Given this list of marker genes Foxa1, Dusp6, Fgfr2, Rdh10 (retinol dehydrogenase 10 (all-trans)), Mbp (myelin basic protein), Fst, Hmgn3, Fgf10, Hoxb9, Maob, Bcl2l1, Lhx6, Edn1, Vldlr, Slc39a8, Fgfr3, Hoxa10, Trim2 (NCBI Gene Id 80890), Pnoc, Tle1, Trmt9b, here is a description of the gene set: Predicted targets of SOX9 that are up-regulated during early prostate development. Mouse Gene Set: SCHAEFFER_SOX9_TARGETS_IN_PROSTATE_DEVELOPMENT_UP species: Mus musculus Cancer cells differentiate along specific lineages that largely determine their clinical and biologic behavior. Distinct cancer phenotypes from different cells and organs likely result from unique gene expression repertoires established in the embryo and maintained after malignant transformation. We used comprehensive gene expression analysis to examine this concept in the prostate, an organ with a tractable developmental program and a high propensity for cancer. We focused on gene expression in the murine prostate rudiment at three time points during the first 48 h of exposure to androgen, which initiates proliferation and invasion of prostate epithelial buds into surrounding urogenital sinus mesenchyme. Here, we show that androgen exposure regulates genes previously implicated in prostate carcinogenesis comprising pathways for the phosphatase and tensin homolog (PTEN), fibroblast growth factor (FGF)/mitogen-activated protein kinase (MAPK), and Wnt signaling along with cellular programs regulating such 'hallmarks' of cancer as angiogenesis, apoptosis, migration and proliferation. We found statistically significant evidence for novel androgen-induced gene regulation events that establish and/or maintain prostate cell fate. These include modulation of gene expression through microRNAs, expression of specific transcription factors, and regulation of their predicted targets. By querying public gene expression databases from other tissues, we found that rather than generally characterizing androgen exposure or epithelial budding, the early prostate development program more closely resembles the program for human prostate cancer. Most importantly, early androgen-regulated genes and functional themes associated with prostate development were highly enriched in contrasts between increasingly lethal forms of prostate cancer, confirming a 'reactivation' of embryonic pathways for proliferation and invasion in prostate cancer progression. Among the genes with the most significant links to the development and cancer, we highlight coordinate induction of the transcription factor Sox9 and suppression of the proapoptotic phospholipid-binding protein Annexin A1 that link early prostate development to early prostate carcinogenesis. These results credential early prostate development as a reliable and valid model system for the investigation of genes and pathways that drive prostate cancer. from publication Schaeffer EM, Marchionni L, Huang Z, Simons B, Blackman A, Yu W, Parmigiani G, Berman DM (PMID 18794802)